The following is a description of a gene set: Human Gene Set: GOBP_SPLEEN_DEVELOPMENT The process whose specific outcome is the progression of the spleen over time, from its formation to the mature structure. The spleen is a large vascular lymphatic organ composed of white and red pulp, involved both in hemopoietic and immune system functions. species: Homo sapiens, and this is the list of marker genes: KMT2A, LIPA, CDKN2B, PCID2, TCF21, FLVCR1, BARX1 (NCBI Gene Id 56033), BCL2L11, PKN1, ONECUT1, BCL3, PPP2R3C, RC3H2, RCBTB2, FAM210B, FADD, SLC40A1, BCL2, EPB42, NFKBIZ, RIPK3, TRAF3IP2, CTC1, ADAM17, COA5, NFKB2, PBX1, NKX2-5, FGF10, POLB, RC3H1, RBM15, CITED2, CACNB4, JARID2, ABL1, NKX3-2, MYB, NKX2-3, CDH17, HOXB4, PITX2